Given this list of marker genes Tbc1d4, Prrt2, Trim9, Coro1a, Ankrd27, Syt4, here is a description of the gene set: species: Mus musculus Mouse Gene Set: GOBP_NEGATIVE_REGULATION_OF_VESICLE_FUSION Any process that stops, prevents, or reduces the frequency, rate or extent of vesicle fusion.